The following is a description of a gene set: Reactome Pathway: Defective visual phototransduction due to RDH12 loss of function part of: Retinoid cycle disease events studied in species Homo sapiens Retinol dehydrogenase RDH12 mediates the reversible, NADP(H)-dependent reduction of all-trans-retinal (atRAL) or 11-cis-retinal (11cRAL) to all-trans-retinol (atROL) or 11-cis-retinol (11cROL) respectively in photoreceptor cells.<br><br>Defects in RDH12 cause Leber congenital amaurosis type 13 (LCA13; MIM:612712). LCA defects are early-onset and severe retinal degenerations that are responsible for the most common cause of congenital blindness in infants and children.<br><br>Defects in RDH12 cause retinitis pigmentosa type 53 (RP53; MIM:612712), an autosomal recessive retinal dystrophy characterised by retinal pigment deposits and primary loss of rod photoreceptor cells followed by secondary loss of cone photoreceptor cells., and this is the list of marker genes: RDH12